Given this list of marker genes FZD6, WNT5A, RYK, PITX3, WNT1, WNT2, FZD3, WNT3A, here is a description of the gene set: The multiplication or reproduction of cells, resulting in the expansion of a cell population in the midbrain. Human Gene Set: GOBP_CELL_PROLIFERATION_IN_MIDBRAIN studied in species Homo sapiens